The following is a description of a gene set: This event has been computationally inferred from an event that has been demonstrated in another species.<p>The inference is based on the homology mapping from PANTHER. Briefly, reactions for which all involved PhysicalEntities (in input, output and catalyst) have a mapped orthologue/paralogue (for complexes at least 75% of components must have a mapping) are inferred to the other species. part of: Regulation of CDH1 Function studied in species Mus musculus Reactome Pathway: Degradation of CDH1 electronically inferred by orthology from the curated human pathway, and this is the list of marker genes: Jup, Psmc4, Psmb4 (proteasome (prosome, macropain) subunit, beta type 4), Psmb5, Ctss, Psmc2, Psmd7, Ctnnb1, Psma5, Psma1, Cbll1, Psmc5, Psmc3, Psma6, Psmd6, Mtbp, Psmd1, Psma2, Psma4, Dnm2, Psmb7, Rps27a, Psmb6, Psmc6 (NCBI Gene Id 67089), Psmd13, Psmc1, Cdh1, Fyn, Rack1, Banp, Psmd12, Ubb, Psma3, Psma7